Given this list of marker genes MAP3K8, MAPK3, FSTL1, SCN4B (NCBI Gene Id 6330), PI4K2A, CNNM3, EYA1, TPRG1, FOXB1, LIFR, CASTOR3P, CRCT1, IL6ST, SLC16A11, METAP2, IRAG1, CTDSPL2, ZBTB16, CEP83, FOSL2, HCAR3, TEK, WNT2B, PPOX, NEUROD6, EHBP1, CLCA1, ERBB4, NRAS, BUB1, RREB1, ADCYAP1, DLC1, RRP36, PPM1D, CACNB2, NCOA5, ENPEP, ZBTB18, ING3, DBNDD2, SERINC3, PDE1A, BRCA2, PBX1, PLAU, CD2AP, EFHB, PPP2R2B, WIPI2, KLHL40, SOX12, KRTAP19-6, C7orf33, CLEC4D, ETV3, VCPKMT, HOXD9, IMPDH2, LRP1, JUNB, CADM1, TXNIP, ARX, PREX2, KIF20A, TCF7, NOTCH4, CCDC120, PPP3CA, MYCL, KBTBD2, SMAD1, GPR174, NYAP1, STK35, ADGRF1, PURA, RAB30, TET2, DUSP4, ATP6V0C, CSMD3, RORB, ASPA, CMTM6, FGF12, CTCF, MAB21L3, GPR4, EXOSC9, ASB16, DTNA, BCL11A, FEN1, ISL1, RANBP3L, MRGPRF, PLXNA2, LUC7L3, RCL1, FOXD3, MAGIX, ABLIM3, PNPLA2, NR0B2, PTGIS, RORC, FRMD4A, ATF7, PTCHD1, PAPPA, GRIK3, NAA15, ZBTB2, SERTAD4, CPNE1, LINC03124, KCNQ5 (NCBI Gene Id 56479), NEDD4, BLCAP, LY86-AS1, NDRG1, SH3GLB2, TFAP4, KDM6A, MYL1, SLITRK5, NTN5, PALS2, MYLK, PRDM1, CPA2, RABGAP1L, HOXA1, PCDH18, STX5, PFDN6, DLX1, ATXN7L2, WASF2, GREM1, HOXA3, HOXA7, POU5F2, PLCB2, VAMP8, PIK3CG, LYPD1, TTC33, DMD, GTF2A1, PDGFB, IGF1R, FST, LRIT1, BNC2, NNT, MAF, CSRNP3, KLHL24, WDTC1, RAB43, APOA2 (NCBI Gene Id 336), NPVF, SMARCA2, UBL3, KCNK4, KLHL1, PLEKHN1, MACO1, ITIH6, AXIN2, MCC, RTL9, TRMT9B, RBM8A, KMT2E, PTH1R (parathyroid hormone 1 receptor), TAGAP, DCP2, RP1, PLEKHH2, MAP2K6, ZFYVE9, CNBP, GABRR1, SOX2 (NCBI Gene Id 6657), POU3F3, CTH, PHACTR3, HOXD10, CILP2, RBM4B, JPH1, SLC24A2, CCND1, FGF20, ARID4A, KLF3, NRAP, PIP5K1P1, ANK2, HAND2, TMEM258, NIN, RBFOX1, RALGPS2, TRIM9, RETREG2, GPR142, MKRN3, SMAD5, TAS2R39, LASP1, SYNPO, NMUR1, ATXN1, HEBP2, PITX2, EN2, NLGN3, EZH1, RAB5B, GRK5, FGF10, TAFAZZIN, TMEM147, RCAN1, SNAP25, LMO3, HOXC4, IGFBP6, DNAJB12 (DnaJ heat shock protein family (Hsp40) member B12), LINC03122, HOXA11, FAM53C (family with sequence similarity 53 member C), USP34, TPP2, INHBA, SUMO1, UCKL1, ZRANB1, CREB5, ANKRD40, SNCAIP, PLAG1, MARCKS, DENND4A, POU4F3, FOXP2, TRPC4, FRMD6, SEMA4G, HSH2D, STAG2, WDR46, MFNG (MFNG O-fucosylpeptide 3-beta-N-acetylglucosaminyltransferase), POU3F4, SLC26A6, CITED2, LAG3, EML1, FGF9, GCNT2, BRAF, TRIM8, RBM4, SAMD11, MITF (NCBI Gene Id 7487), STK40, SCUBE3, AP4M1, FAM169BP, PLPP3, SOBP, PALM, CRH, SMAD9, COCH, SIN3A (NCBI Gene Id 25942), LINC00649, SLC16A6, POLR2L, NAP1L5, TRIM2, WBP4, ZBTB7A, MTMR14, NR1H4, AHNAK, FOXO3, C1QTNF3, HARS2, RASSF6, DOC2B, SLC10A7, PDE6D, NINJ2, TMEM59, SSBP3, SAMTOR, OGA, STOML3, KCNJ2, RPS27, ENOX1, RARG, ROR1, SLC4A1, CD2BP2, TAF5L, GPM6A, NDUFA5, DUSP10, TNFRSF19, KCTD15, ROBO1, PIAS1, TRIM42, HPN, SCRN1, NEBL, ASCL1, PLA2G2F, AUH, PIK3C2A, PTMS, TTLL6, CAD, ABTB1, TBX4, FLI1, NCDN, KLF12, DHX8, ACSL1, SPRY4, FBXW7, SMURF2, CHD2, KCNA4, TMCC2, HNF1A, TBC1D17, HOXA5, ASIC2, ZNF532, KCNJ5, OFCC1, GABARAPL2, OLIG3, ANXA2, TGIF1, TLE1, KCNA1, LPP, AXL, OARD1, EIF4EBP2, MAPK10, NDST4, TCF15, DST, RXRB, CCDC9B, NTF3, CCT6B, BRD8, FOXG1, SYT10, SCAF8, ZFHX4, YTHDC1, PRKACA, NFIX, DDX17, L3MBTL1, CMIP, DMKN, PTP4A3 (NCBI Gene Id 11156), TRIB1, FAXC, SIAH3, MXD1, ENPP2 (ectonucleotide pyrophosphatase/phosphodiesterase 2), MXRA8, GDNF, TNIP1, TCF4, WNK2, CXCL5, VCAN (versican), CLDN8 (claudin 8), GRIK2, CRTC2, BMAL1, VGLL3, PDLIM3 (PDZ and LIM domain 3), DHRS3, HTN1, SPOCK2, GPR137B, MDK, HMCN1, KRT1, DAPP1, RBP3, NR4A1, SUPT4H1, TCP11L1, TCP11L2 (t-complex 11 like 2), LONRF1, CLGN, CLIP2, PNRC1, IRS4, CCN1, SLC2A4, CAMK1D, SIM1, JADE2, CADPS, CD109, HOXB4, AMDHD2, GPR63, RETREG1, PXK, PDGFC, UBXN10, HOXA10, ZNF581, ZMAT4, XPO7, AP1G2, IL25, SLC25A39, TMCC1, FAM135B, SHOX2, NTN1, PPARGC1A, CFAP161, TSPAN5, ADAM12, RNF39, KRT84, CCER1, FGL2, RAPGEF6, E2F3, DDX5, IL21, TMOD3, NOB1, CDKN1C, ZBTB10, NKAPP1, NRG1, EMP1, NFYA, SLC39A7, KANSL2, HSD17B11, PCYT1B, COQ8A, SLC38A2, PMCH, TFDP2, CBFA2T2, KCNH2, SLC35D1, PIK3IP1, TMEM94, ANP32A, PCDH9, VASN, CPN1, ATF2 (activating transcription factor 2), UNC45B (NCBI Gene Id 191583), PANK1 (NCBI Gene Id 53354), PKIA, KCNG3, SLITRK6, PCSK5, CALD1, MDM2, SMG1, LGALSL, WBP1L, ABCB1, FIS1, FOS, PLS3, SELENOP (NCBI Gene Id 6414), SQSTM1, SLC34A3, IL16, COLEC10, C1orf43, ZHX2, RIPOR1, WDR13, DHX40, KCNN3, SULF1 (NCBI Gene Id 23213, sulfatase 1), KLF3-AS1, CELF6 (NCBI Gene Id 60677), ASCL4, SLITRK2, FHL2, GPBAR1, PHAF1, SKAP1, BMP10, SOCS1, FOXJ3, LEMD1, DDB1, BCL2L13, LIN54, PTBP3, PDCD1LG2, CPEB3 (NCBI Gene Id 22849), BDNF, NTRK3, PPP1CB, ST3GAL2, NEUROD1, MARCKSL1, ARK2N, COLEC12, HSD11B1, SLC30A8, IBSP, ADRB1, LMO4, SGTB, MEIS1, SRSF6, DOCK3, GRB7, NPDC1, FLRT3, PDK4, PPP1R12A, TLE3, INSR, ZNF711, FAM89A, MORF4, CYRIA, RAD21, KLHDC2, PBXIP1, MBNL1, KCNJ12, KIF19, TIMM8A, DENND4C, KY, CLSTN1, DYNC1I1, SZT2, CEPT1, KLHDC3, SCAMP1, MSMB, APOB, HOXB8, PHLPP1, IFIH1, RGS1, DSG4, NDRG2, AKT1S1, ZNF580 (NCBI Gene Id 51157), KCTD12, MORC1, NFATC3, LRRC1, C22orf15 (chromosome 22 open reading frame 15), ZBTB5, SLC38A3, HSF2, MGLL, IRF4, VIT, PHEX, KRTAP17-1, ORMDL3, HESX1, SRPK2, ZBTB37, RNF17, ETS1, LZTS2, S1PR1, MAFF, STK3, ING1, IMMP2L, OSR1, DCAF11, GRID2, RUNX1, MMP13, TGFB3, STARD13, CREBL2, NR4A2, POU2F1, MEPE, PRKCH, MSL2, CIMAP1C, RABL6, ABI3BP, NDUFA4L2, GALNT3, ERG, HOXB9, ZFP36L2, CRB1, CHCHD7, ZNF362, HOXC8, PRDX6, MGAT4B, TBCC, NUDT18, NLN, MYT1, PPT2, RHOQ, MXD4, UNC79, DAB2IP, SLC25A5, POU2AF1, ADAMTS13, ESYT3, CASC2, ESRRG, OCLN, ZNF219, CFL2, ERBB2, ITSN2, SDCBP2, VSTM2A, ADGRB3, LINC00173, ZMYND8 (zinc finger MYND-type containing 8), GNB2, PCSK1, PPP2R3A, KRT85, MOSPD1 (NCBI Gene Id 56180), NR3C1, EDN1 (NCBI Gene Id 1906), FGF14, ALKBH5, COX7A2, KLF14, HBP1, DCN, FYN, CLPX, SOX5, NEO1, PDZRN4, ZNF385B, HR, EPN1, IP6K2, ASAH1, TBXAS1, TSPYL4, MBNL2, CDKN1A, SIDT2, ZNF830, CREBRF, SLC12A6, H3-3B, GNAO1, MYC, PAGR1, EPHB2, RMND5A, SESN3, BCL11B, TSPAN4, STAT6, PDRG1, ATXN7L1, MCM7, TFEB, MAP3K13, DUSP1, TRIM63, HIBADH, MN1, BIN1, ART5, DDIT4, TAF8, ARHGAP30, BMP3, SBF2, HSPG2 (heparan sulfate proteoglycan 2), WNT2, KAT6A, MEA1, BTBD3, CYB5R3, HCAR2, CNPPD1, ARHGAP12, FOXN3, SEMA6D, IKZF4, RANBP9, EMX2, PROX1, CUEDC1, BTBD8, SLC25A28, CNIH2, MARCHF5, HHIP, USP3, UHRF2, TCF12 (transcription factor 12), LGI1, CSDE1, NGEF, RASGEF1B, BCAS3, PDE7A, ASXL2, KLF9, NRN1L, TIAM1, FBXL22 (NCBI Gene Id 400380), CILK1, TLCD1, GPRC5C, ZFYVE1, OPA3, GOLGA1, IGF1, BMI1, DNAJB4, BUB3, ACSF2, CDK14, CGA, GNPNAT1, TCEANC2, EI24, HARS1, CCN2, TLK2, ASB7, ZBTB22, EPHB3, EGLN1, KIZ, SMOX, HOXC10, GSE1, CEP95 (NCBI Gene Id 90799), THRA (NCBI Gene Id 7067), PLEKHA5, MATN2, KCNJ13, TRERF1, STX16, HOXC6, BMP2, GRHL1, MED8, POLD4, ACVR1C, GJA1 (gap junction protein alpha 1), LTB, MLIP, SLC26A7, ELMO1, SHROOM1, TSC22D3, SLC4A10, ISG20, GRK6, ELK3, FMR1, FOXO1, ZNF521, MECOM (MDS1 and EVI1 complex locus), NF1, FAM13C, MEX3B, DOCK5, TMEM81, BIK, FAM110A, GLYR1, MBTPS1, TMPRSS15, HIPK1, P2RX7, MID1, STARD10, DPP10, ZNF423, A1CF, RASD1, POU3F2, ANKRD28, SLU7, SNX13, GFRA1, PCDHA4 (NCBI Gene Id 56144), MBOAT2, NID2, ID2, ZFAND6, TOB1, LCP2, CCDC106, SATB2, MTTP, ARHGEF2, CDKN1B, RORA, AKT2, UST, KIF21A, TCF7L2, STAP1, C1QTNF6, TSC1, GPX1, ADNP, SYT6, PHF8, ELOVL6, NKX2-1, ETV5, TRPS1, WEE1, CRISP1, RARA, PHF21B, C17orf58, RPS6KA5, CSNK1G3, MLLT6, CLDN2, LNPK, REEP4, SPEN, RNF128, GADD45A, KCNJ15, JUP, CLN5, LRP5, FRY, LINC01101, EIF3J, DCSTAMP, SALL3, ULK1 (NCBI Gene Id 8408), FOXO4, TNS2, CHD1, MMP16 (NCBI Gene Id 84257), NSD3, GPR61, CNGB3, NIM1K, SLC23A3, PCDHGA5, PJA1, TENM1, NSG2, IKZF2, LINC00474, KLC2, ALDH4A1, CCDC89, CDX2, PITPNC1, ARFGEF1, CALM2, HIC2, ARHGEF6, MCTS1, PHF12, CACNG2, GPRIN3, CRY1, LINS1, EXT1, OSR2, PTCH1, BMP4, BCLAF3 (NCBI Gene Id 256643), MAML3, TAFA1, GMFG, CXXC5, PKN2, SCRN3, MSC, KRTAP12-3, PELI2, ETV1, TXNDC12 (NCBI Gene Id 51060), TSPAN8, BACH2, EFEMP1, TREX2, ABCA1, BMP5, RAPGEFL1, POLR1G, GTF2B, OTUD7B, ZDHHC3, MAP4K5, UBE2H, GPR18, NFIB, here is a description of the gene set: Human Gene Set: RTAAACA_FREAC2_01 species: Homo sapiens Genes having at least one occurrence of the highly conserved motif M36 RTAAACA in the regions spanning 4 kb centered on their transcription starting sites. This matches the FOXF2 transcription factor binding site V$FREAC2_01 (v7.4 TRANSFAC). from publication Xie X, Lu J, Kulbokas EJ, Golub TR, Mootha V, Lindblad-Toh K, Lander ES, Kellis M (PMID 15735639) Comprehensive identification of all functional elements encoded in the human genome is a fundamental need in biomedical research. Here, we present a comparative analysis of the human, mouse, rat and dog genomes to create a systematic catalogue of common regulatory motifs in promoters and 3' untranslated regions (3' UTRs). The promoter analysis yields 174 candidate motifs, including most previously known transcription-factor binding sites and 105 new motifs. The 3'-UTR analysis yields 106 motifs likely to be involved in post-transcriptional regulation. Nearly one-half are associated with microRNAs (miRNAs), leading to the discovery of many new miRNA genes and their likely target genes. Our results suggest that previous estimates of the number of human miRNA genes were low, and that miRNAs regulate at least 20% of human genes. The overall results provide a systematic view of gene regulation in the human, which will be refined as additional mammalian genomes become available.